The following is a description of a gene set: Any process that modulates the establishment or extent of a membrane potential, the electric potential existing across any membrane arising from charges in the membrane itself and from the charges present in the media on either side of the membrane. studied in species Mus musculus Mouse Gene Set: GOBP_REGULATION_OF_MEMBRANE_POTENTIAL, and this is the list of marker genes: Nrxn1, Pink1, Wnt7a, Trpv1, Grik3, Grik2, Cav3, Kcnh2, Grin2b, Cdk5, Clcn1, Scn2a, Gabrb1, Kcnma1, Atp2a2, Ndp, Kcnk1, Kcnip2 (Kv channel-interacting protein 2), Sod2, Atp1b3, Tmem135, Ntsr2, Eif4a3, Trdn, Kcnd1, Kctd8, Neto2, Cntf, Rnf122, Scn3b, Ank2, Ckap5, Gja1, Phox2b, Chrna6, Fkbp1b, Pias3, Chrnb1, Begain, Abcb5, Hcn2 (NCBI Gene Id 15166), Mecp2, Nppa, Slc29a1, Smad3, Prkar1b, Ntrk3, Pip5kl1, Snca, Slc6a4 (solute carrier family 6 (neurotransmitter transporter, serotonin), member 4), Oprm1, Calm3, P2rx2, Kcng3, Stox1, Pex5l, Dbn1, Kcnh1, Nos1ap, Kcne4, Kcnt1, Flna, Met, Asic5, Cck, Tbx18, Npy2r, Kcnv2, Kcnmb4, Reln, Cnih3, Nedd4l, Chrna4, Slmap, Kcnk13, Cav1, Fgf14, Atp1b1, Dmd, B2m, Trpa1, Oga, Npas4, Rapgef4, Snta1, Nr3c2, Prelid1, Cacnb2, Sod1, Slc8a2, Smad7, P2rx1, Chrnb3, Mapt, Cntnap2, Ppa2, Kcnh5, Glra4, Jup, Slc8b1, Ltf, Kcnh6, Prkce, Grip2, Mapk8ip2 (NCBI Gene Id 97995), Gjd2, Gba1, Dgki, Nlgn4l, Glra1, Scn4a, Nnt, Kcna10 (potassium voltage-gated channel, shaker-related subfamily, member 10), Kcnj9, Nup155, Cnga2, Drd4, Kcnj11, Kcne5 (potassium voltage-gated channel subfamily E regulatory subunit 5), Fgf12, Kcnc1, Insyn2a, Tbc1d24, Glrx, Kcns2, Bad, Chrnb4, Atp1a1, Mtnr1b, Slc4a3, Glrb, Gja5, Gnaq, P2rx6, Grin2a, Akap9, Hnrnpa1, Chrnb2, Mllt11, Gabra3, Zmynd8 (zinc finger, MYND-type containing 8), Zmpste24, Mfn1, Grik4, Il1rn, Shtn1, Psen1, Adra1a, Hcrt, Gpr35 (NCBI Gene Id 64095), Cnga1, Nps, Ccn6, Bak1, Kcnk6, Cln3, Grid1, Kcne2, Gimap5, Akt1, Fgf13, Grk2, Pmaip1, Kcns3, Celf4 (CUGBP, Elav-like family member 4), Kcnf1, Grin3b, Kcna6, Insyn1, Gm2990, Usp53, Bok, Cxadr, Scn1b, Ndufs1, Lrrk2, Chrm5, P2rx4, Best2, Gclm, Gclc, Casq2, Gpr88, Kcnc4, Akap6, Cnr2, Myh14, Ctns (cystinosis, nephropathic), Rims2, Tafa4, Chrna1, Drd1, Gria4, Myoc, Kcne3, Cnih2, Ywhah, Chrna3, Kcng1, Mir451b, App, Rangrf, Crtc1, Atp1a4, Prdx3, Slc25a33, Gria3, Ptpn3, Tmem25, Hcn1, Slco1b2, Fzd9, Slc4a11, Nalcn, Alb, Wdr1, Kmt2a, Kcnk2, Abcd1, Ano6, Slc26a3, Tac1, Tmem108, Cacna1d, Asic1, Casr, Cftr, P2rx3, Kctd16, Htr3a, Calm2, Kcne1, Bcl2l1, Tbx5, Cacna1h, Stx1a, Prkcz, Cd36, Mir451a (microRNA 451a), Kctd7, Dcdc2a, Cacna1a, Gabra5, Mul1, Il6 (interleukin 6), Cacna1g, Shank1, Hcn3 (NCBI Gene Id 15168), Scn11a, Rims1, Kcnmb2, Cux2, Kdr, Tspan9, Camk2d, Kcnv1, Shank3, Ndufs4, Cdkn2a, Bco2, Ssh1, Gper1, Bnip3, Kcnk4, Ppp3ca, Kcnn4, Pank2, Cntnap1, Nlgn1, Bid, Pkp2, Hnf1a, Grin2d, Mtch2, Piezo1, Kcnk9, Cacng2, Slc1a7, Scn1a, Kcna1, Gabrr2, Grm1, Kcna3, Dsc2, Nedd4, Jun, Stx1b (syntaxin 1B), Gna14, Chrna10, Kcnh7, Wwp2, Asic2, Adcy10, Plk2, Glra3, Pten, Rnf207, Rbfox2, Kcna4, Cacna1i, Kcna2, Gna11, Grik1, Cbln1, Kcnd2 (potassium voltage-gated channel, Shal-related family, member 2), Parp1, Kcnh8, Afdn, Ghrl, Mef2c, Fxyd1, S1pr2, Slc9a1, Cacna1c, Tacr1, Bves, Kcna7, Dvl1, Scn3a, Kcnb2, Kcnj5, P2rx7, Arl6ip5, Adora1, Hsh2d, Gabrg2, Akap7 (A kinase anchor protein 7), Alox12, Atp1a3 (NCBI Gene Id 232975), Grid2, Ehd3, Chrna2, Kcnc2, Src, Ngfr, Dpp6, Ubb, Kcnmb3, Scn2b, Pclo, Oprd1 (opioid receptor, delta 1), Bax, Dlg4, Trpm4, Ucn3, Mtmr2, Rimbp2, Gabra1, Gprin3, Chrnd (NCBI Gene Id 96934), Tmem161b, Kcnc3, Tusc2, Prkn, Edn1 (endothelin 1), Tnf, Piezo2, Kcnq2 (potassium voltage-gated channel, subfamily Q, member 2), Calm1, Glra2, Rgs7, Ndufc2, Hcn4, Kcnn2, Ppif, Slc17a7, Bdnf, Trpc4, Gabrb3, Slc4a4, Abcc9, Kcnb1, Kcnj10, Abcc8, Kcnj2, Ptk2b, Agt (angiotensinogen), Atp1a2, Trem2, Myc, Kcnh4, Slc34a1, Xirp1, Scn9a, Ntrk2, Ntsr1, Sumo1, Slc4a8, Mtor, Nlgn3, Foxp1, Gabra2, Grin1, Gimap3, Unc13b, Gpd1l, Grik5, Kcnd3, Atp1b2, Ifng, Kcnq1, Popdc3, Scn5a, Mfn2, Ank3, Dynll1, Cnr1, Kcng4, Rims3, Pmp22, Kcnq3, Neto1, Dmpk, Ppp2r3c, Tspo, Rab3gap1, Adrb1, Slc39a8, Mpp2, Nlgn2, Adora2a, Rgs7bp, Npff, Rims4, Dsg2, Slc25a36, Adrb2, Abat, Chrna5, Ffar3 (free fatty acid receptor 3), Kcnk3, Chrna7 (NCBI Gene Id 11441), Kcns1, Ywhae (NCBI Gene Id 22627), Gabbr1, Col6a1, Park7 (NCBI Gene Id 57320), Fhl1, Slc8a1, Ndufs6, Pawr, Pid1, Ppp1r9a, Igsf11, Clcn2, Gpr39, Eif4a3l2, Trpc5, Ucp2 (NCBI Gene Id 22228), Nrcam, Tspan4, Ano1, Slc24a4, Npr2, Ryr2, Dld, Dsp, Vcp, Gna15, Bbs10, Kcnh3, Grin3a, Sez6, Ctnna3, Lipa, Cx3cl1, Slc25a27, Kcna5, Mtln, Rgs4, Igsf9b, Kcnip1, Scn4b, Got1, Ptn, Gabra6, Casp1, Eif4a3l1, Chrna9, Gria2, Asic3, Slc8a3, Sh3gl1, Cacna2d1, Kcng2, Clic1, Gabrd, Baiap2, Dlg1, Kcnj6, Spart, Slc1a6, Bin1, Grin2c (NCBI Gene Id 14813), Kctd12, Gria1, Cacnb4, Rack1, Dcn, Chrm1, Kcnj8, Bcl2, Gsk3b, Slc26a5, Scn10a, Bnip3l, Chrne (cholinergic receptor, nicotinic, epsilon polypeptide), Creb1, Htr3b, Kif5b, Nos1, Gabrr1, Pycr1, Atp5if1, Cldn19, Agrn, Atxn1, Actn2, Gabrg3, Kcnj3, Gabrb2, Fmr1, Chrng, Scn8a, Cacnb3, Adcyap1, Popdc2